The following is a description of a gene set: Mouse Gene Set: GOBP_CELLULAR_RESPONSE_TO_LITHIUM_ION Any process that results in a change in state or activity of a cell (in terms of movement, secretion, enzyme production, gene expression, etc.) as a result of a lithium (Li+) ion stimulus. studied in species Mus musculus, and this is the list of marker genes: Fas, Cdkn1b, Nfatc4, Pparg, Cebpa, Slc13a5, Shh, Cdh1, Adcy7, Slc13a2, Fabp4, Lig4, Calr, Nfatc3, Id2, Myog, Gsk3a